Given this list of marker genes STX17, STX6, STX11, VAMP7, TSNARE1, STX7, SNAP29, STX1B, VAMP3, DOC2B, STX5, SNAP25, SNAP47, BET1L, STX18, GOSR2, USE1, STX10, VTI1B, STX12, VAMP2, GOSR1, STX2, SNAP23, BNIP1, BLOC1S6, STX16, STXBP5L, STXBP5, SNX4, STX4, STX8, NAPA, VAMP8, STX19, STX1A, VTI1A, CPLX1, NAPG, BET1, VAMP1, CPLX4 (complexin 4), STX3, CPLX3, VAMP4, CPLX2, SYN2, NAPB, YKT6, here is a description of the gene set: Human Gene Set: GOCC_SNARE_COMPLEX studied in species Homo sapiens A protein complex involved in membrane fusion; a stable ternary complex consisting of a four-helix bundle, usually formed from one R-SNARE and three Q-SNAREs with an ionic layer sandwiched between hydrophobic layers. One well-characterized example is the neuronal SNARE complex formed of synaptobrevin 2, syntaxin 1a, and SNAP-25.